The following is a description of a gene set: Human Gene Set: GOBP_LIPID_METABOLIC_PROCESS species: Homo sapiens The chemical reactions and pathways involving lipids, compounds soluble in an organic solvent but not, or sparingly, in an aqueous solvent. Includes fatty acids; neutral fats, other fatty-acid esters, and soaps; long-chain (fatty) alcohols and waxes; sphingoids and other long-chain bases; glycolipids, phospholipids and sphingolipids; and carotenes, polyprenols, sterols, terpenes and other isoprenoids., and this is the list of marker genes: MTMR11, GGT7, DHRS3 (dehydrogenase/reductase 3), PPARD, FUT6, GSTM1, RDH13, ATP5F1A, GAL3ST4, DGAT2, AIG1, CHKB, ST3GAL3, DKKL1, ABHD1, BRCA1, RBP2, ORMDL1, KAT5, LPCAT4, PLTP, CYP4Z1, ADORA1, PLAAT5, PITPNM3, TEX2, MAPK14, UGCG, MBOAT1, H6PD, PRKAB1, ELOVL3, ACSS2, PAFAH2, ABHD11, PDE3B, SPATA18, GPX5, DECR1, RNF213, PLA2G12B, ZMPSTE24, GGCX, TM6SF2, ACBD4, TMEM86B, HSD17B11, ALDH8A1, GDPD3, OXSM, ELOVL4, CYP2B6, PIGC, LRP1, NFKB1, CRK, PLCH1, ENDOU, ATP6V1B1, B4GALNT2, SDR42E1, PIP4K2A, CYP3A5, ABHD12B, FABP2, SLC44A3, GATA6 (GATA binding protein 6), EDF1, CYP2A6, LTC4S, GPR82, MIR192 (microRNA 192), CYP2D6, BBS1, PLA2G3, GFI1, FADS6, ACSL4, PDSS2, TTR, PDK3, ACSL1, OSBPL9, PAQR3, ST8SIA4, SUMF1, PGAP1, ECH1, CHAT, CDS1, PIK3C2G, ALDH1A2 (NCBI Gene Id 8854), ASPG, PDE3A, PCYT1A, LIPN, P2RX1, STAT5A, PLA2G4B, PLPP6, FADS2, SMPD4, CYP4B1, ADM, CYB5R3, CRTC3, DHRS4L2, ECI2, RDH11, APOD, ABCG1, PLA2G5, PIP4P1, GLA, CYP39A1, SLC44A4, GPX4, PTPRQ, MIR1-1, KLHL25, HCAR1, ANO9, ADH5, HACD4, CRKL (CRK like proto-oncogene, adaptor protein), APOA4, FUT2, MIR185, GGT3P, SMPDL3B, LEPR, DDHD1, CYP7B1, HSD17B4, SULT1A3, ASXL3, HCAR2 (hydroxycarboxylic acid receptor 2), GSTM2, MIR127, CYGB, RPTOR, PNLIPRP2, OLAH, B3GALT2, HMGCR, TPRA1, BAX, ACAD10, NFE2L1, ELOVL2, ST8SIA2, BECN1, PLA2G10, GHSR, CRABP2, SCCPDH (NCBI Gene Id 51097), ETFB, PRKAR2B, PDGFRA, GBGT1, UGT2B28, NUDT8, LYPLA2, EDNRB, UCP3, ABHD16B, SORL1, THRA, PIP5K1C, PDSS1 (NCBI Gene Id 23590), TTC7A, PTGIS, PRKD3, ACBD5, ACSBG2, IDI2, FGF19, DHRS7, PIGV, ABHD5, SIRT2 (NCBI Gene Id 22933), PRXL2B, UVRAG, APOB, IDH1, CYP2C18, ACSM2B, TM7SF2, SLC16A1, CRPPA (CDP-L-ribitol pyrophosphorylase A), MTMR9, DNAJC15, ACSL3, LRP5, PGAP6, FLVCR1, ANGPTL4, FA2H, MMUT, TAFAZZIN, PIP4K2C, ACOT12, UGT2A1, PEMT, CFTR, B4GALT6, TMEM150A, PIK3R5, SREBF2, CYP8B1, GNPAT, UGT2B4 (NCBI Gene Id 7363), MTLN, PIGT, SULT1A2, ETFDH, SYNJ1, BGLAP, PCK2, CYP4A22, MCEE (NCBI Gene Id 84693), ST3GAL4, SMPD1, ACSF3, GM2A, WNT10B, B4GALT4, HTR2B, SH3YL1, ABCA1, MIR33A, G6PC1, TBXAS1, LCLAT1, CERS2, CTDNEP1, ITPKB, COQ2, HDLBP, FGF1, ACSM4, PLAA, IP6K1 (NCBI Gene Id 9807), TPP1, ACSM2A, ABCG2, PRKAG2, GPAM, AOX1, CYP2E1, UGT2B17, PECR, BMX, RIDA (reactive intermediate imine deaminase A homolog), ATM, ADHFE1, SPTLC2, APOF, GGT1, PDK2, ATP1A1, PI4K2A, NUDT19, PLD6, LPIN2, EFR3A, SLC27A3, PTPMT1, SAMD1, INPP5J, HDHD5, NEU3, ALDH3A1, PI4KB, HEXB, CHKA, CYP26A1, IMPA2, ID2, ACOX1, MFSD2B, B4GALNT1, ACAA1, ZPBP2, MPPE1, CPT1B, SDR16C5, SMPD2 (NCBI Gene Id 6610), SPHK2, MBOAT2, NUS1, RDH14, LRAT, ADH4, TMEM135, C20orf173, VLDLR, TPK1, CES1, ILVBL, CYP2A13, ALDH1L2, RDH8, MECR, MED1, IP6K3, SREBF1, ABCA3, DGAT2L6, IAH1, CYP4A11, HPGDS, DGKI, SPTSSA, AKR1C3, OPA3, ACOT8, NR0B2, ITPKC, PLD4, DGKE, CAPN2, SPHK1, FKRP, ALKBH7, FAH, PLSCR1, PCYT1B, AVP, AFP, CES2, C3, MIR16-1, TSKU, KPNB1, NAGA, ST8SIA1, ENSG00000293349, PLA2G2C, TBL1XR1, APOA1, FABP3, RUBCNL, CH25H, ABCA8, LEP, GGTA1, PRKCE, PRKD2, PIGH, LIPK, UGT1A6, POR, GOLM1 (NCBI Gene Id 51280), PLAAT3, CNEP1R1, CREB1, GPER1, SGMS2 (NCBI Gene Id 166929), PLD1, MFSD8, PDK4, AVPR1A, NR1H4, ABHD8, GDPD2, FAM135B, FUT5, MIR98, FAXDC2 (fatty acid hydroxylase domain containing 2), ENPP6, SULT1E1, CTHRC1, MGST2, LGMN, NSDHL, ETNPPL, SEL1L, PRKAA2, ISYNA1, PLD2, LPGAT1, PEX2, PLA2G2D, PIGU, TYRP1, ADGRF5, TNXB, MBOAT7, PLEKHA1, NCOA2, INPP5B, ACOXL, ABCD4, NEU2, ALDH1A1 (NCBI Gene Id 96075), ZNF202, A3GALT2, ALOX5, DGKH, OSBPL8, ADTRP, SIRT3, FITM1, PNPLA7, DGKD, DISP3, ACACA, INPP5A, MGLL (monoglyceride lipase), CPT2, NAGLU, CPT1A, GDPD5, ABHD2, HSD17B13, SFTPB, PORCN, ACOX2, FAAH2, HMGCLL1, ZNF750, OSBPL10, PAQR4, BDH1, APOC1, MIR548P, SLC22A13, HADHA (hydroxyacyl-CoA dehydrogenase trifunctional multienzyme complex subunit alpha), FMO2, GGPS1, SULT1C3, ECHDC3, MIR27A, IFNG, DEGS2, ORMDL3, IGFBP7 (insulin like growth factor binding protein 7), LRCOL1, LDAH, APOBEC1, WNT4, MTMR14, PLCG1, APOBR, AGPAT2, BCAT1 (branched chain amino acid transaminase 1), NEU4, PLIN1, HPS6, AMACR, PNPLA1, MIR766, PLCH2, ABCA7, PLCL2, PLAAT2, PLD3, PIK3CB, AADAC, TECR, PPT2, CTH, DHRSX (NCBI Gene Id 207063), MTMR12, GPRC6A, MBOAT4, ERRFI1, CERT1, CCN1, HACL1, ACSM5, TREM2, ETFA, TYSND1, FAR2, PLA2G2F, CYB5R2, APOC4, CLSTN3, EBP, AKR1B10, CDIPT, ADIPOR2, PC, GNAI1, ACOT7, GDF15, TTPA, HADHB, ADH1C, LCT, DAGLA, ACAT1, LPCAT2, RDH10, TPTE2, SERPINA12, AGPAT5, PRKAB2, PANK2, CUBN, NEU1, VAC14, CD36, NSMAF, LIPF, KDSR, PLA2G15, GPR180, NR1D1, SCARB1, PLB1, MIR132, GBA1, ABCB11, EIF6, PROX1, GK2, SULT4A1, BCO1, NR1D2, FUT9, UGT1A9, PIK3R1, DOLPP1, CYP11B2, PIGG, PIGK, ABCC9, DKK3, NR5A1, FIG4 (NCBI Gene Id 9896), HTR2A, PGAP3, GPAT2, EGR1, PLBD2, ZNF670, RPE65 (retinoid isomerohydrolase RPE65), DPEP2, CAT, CBR1, CIDEB, LPA, GSTA1, FUCA1, CHP1, MCAT, RBP1, ACSS3, HSPG2, CWH43, HSD17B10, WDTC1, CROT, ACACB, CYP4F2, MIR206, MIR27B, HSD3B2, ABHD3, PLPPR5, PIGP, UGT1A1, AGK, HTD2, G6PD, PTGR2, GC, ALOX15B, NDUFS6, PLCE1, ACLY, CLN3, SGPP1, DEGS1, ACADVL, PLA2G4F, HSD3B7, CERS5, PI4KA, HNF4A, LDLRAP1, PLA2G1B (NCBI Gene Id 5319), MIR29B1, NR1I2, SLC27A2, CYP2U1 (cytochrome P450 family 2 subfamily U member 1), GSTM4, PGP, VPS54, DGKA, AWAT2, KAT2B, MVD, ALDH3B2, AACS, CERS1 (NCBI Gene Id 10715), ELOVL6, PLCB4, PIGL, OGT, DAGLB, UGT1A4, CERKL, MOGAT3, LRP2, MTMR10, AKT2, UGT1A7, MTMR3, MBTPS2, PRMT3, ACADSB, MOGAT2, CYP1A1, HAO2, HSD11B2, ACAD9, CYP2C8, ACSS1, GLB1, HACD1, CIDEC, SCARF1, TWIST1, LMF1, CERS6, ACOT1, ZFP69, PLA2G6, DPM2, B3GNT5, SDS, PLAGL2, EPHX1, PSAP, ALDH3A2, SULT2B1, TAMM41, COMT, FDPS (farnesyl diphosphate synthase), INPP4A, PIP5KL1, EPHX3, ALOX12B, ASAH2, IP6K2, HSD17B2, ARV1 (NCBI Gene Id 64801), PLBD1, OSBPL3, SLC30A5, DHCR24, GGT5, GGTLC1, CERS3 (NCBI Gene Id 204219), CLPSL2, PIGN, BSCL2, FMO4, THEM4, ACOT2, DDX20, INHBA, NR3C1, SPTSSB, APOC3, PLCZ1, SLC44A1, PLPPR3, M6PR, FGF23, PROCA1, FABP5, GK5, CHST10, SLC27A1, PTGS1 (NCBI Gene Id 5742), AQP8, OSBPL7, ERG28, PGAP2, SCD5, SIRT6, RDH5, SLC22A24, CYP7A1, LHCGR, ACER1, GPR146, APOH, PAM, ACADM, DHH, EEF1A2, HSD17B3, TNFAIP8L3, IDI1, XBP1, LPCAT1, PNPLA4, INPP1, STARD3, TMEM43, PIK3CA, PIGA, HSD17B6, ALDH3B1, GAL3ST3, PLPPR2, ST8SIA5, DHRS9, AVIL, OSBPL6, PI4KAP2, CYP27C1, CLN8, HSD17B14, EDN2, PITPNB, BCO2, PLA2G4C, SERPINA6, RORA, PIP4P2, PIAS4, PLPP3, PRKAG3, ELOVL7, ADGRF1, PAFAH1B3, SERINC1, PITPNM1, EDN1, AKR1C1, INPP5F, CPS1, CYP3A4, PITPNM2, SORBS1, PIP4K2B, PIK3CD, SMPDL3A (NCBI Gene Id 10924), ITPKA, NDUFAB1, PAFAH1B2, DBI, SLC27A4, PLPP4, ADH6, DNAJC19, HINT2, FITM2, PTEN, PLA2G7 (NCBI Gene Id 7941), GAL3ST2, ADRA2A, GDPD1, RICTOR, DPM1, MVK, MIR182, PIP5K1A, SNAI2, BMP6, MIR342, LACTB, CYP1B1, CYP27A1, B3GALT1 (NCBI Gene Id 8708), APOC2, SCPEP1, SPP1, GBA3, AGPAT1, MID1IP1, SMG1, ACAD11, ANGPTL3, INSIG2, ANGPTL8, ST6GALNAC3, ABCB4, TMEM38B, SOX9, GSTA3, CEPT1, ASAH1, GGT6, PLA2G2A, APOL2, CYP3A7, CYP1A2, UGT1A10, CYP2F1, ZBTB20, OCRL, ERLIN2, UGT2B11, CYP46A1, PTPN11, PIK3R3, OSBPL1A, UGT2A2, PSAPL1, SPNS2, TMX1, ARMC5, ADIPOQ, PLCD4, CYP4F11, PLCG2, KIT, PIGM, ALDH1A3, CYP3A43, HAO1, ABCA2, ECHDC1, GPCPD1, MTM1, CYP26C1, CIDEA, SRD5A1, ACSF2, FUT4, SELENOI, GPAA1, LSS, GPIHBP1, INPPL1, PRKCD, GPLD1, CYP27B1 (cytochrome P450 family 27 subfamily B member 1), CYP4X1, LPCAT3, ACAD8, FAR1, AWAT1, ADH1B, CERS4, PISD, TSPO, BDH2, NKX2-1 (NK2 homeobox 1), CYP19A1, SERINC2, PPM1L, AGPS, PDGFB, MBTPS1, B4GALT3, STAT5B, AGT, ST6GALNAC6, DHCR7, MECP2, PIK3C3, GALC, B3GALNT1, SULT2A1, CLCN2, CGA, RDH12, PPARGC1A, UGT8, PLCXD2, PLPPR4, MAPK1, PLCB3, LGALS13, CLPSL1, MIR195, CYP2C19, FAAH, BCL11B, PLCL1, FUT7, PRLR, LIPI, ST8SIA3, IL1B, PIGQ, EBPL, IPMK, PBX1, ARSA, ESR1, GGTLC3, NAAA, ABCD2, MIR9-1, CREBL2, ECHS1, SEC14L2, FDX1, ACSL6, FADS1, CHPT1, ABO, THEM5, CYP26B1, ASAH2B, APPL2, SCAP, DPM3, AKR1B1, PDK1, ECHDC2, AKR1C2, PLA2G12A, MBLAC2, PNLIPRP1, PNPLA3, PTGDS, EPHX2, HYCC2, SH3GLB1, HMGCS1, TTC7B, SIRT4, CPNE1, NCOR1, SCD, GSTP1, ACSM3, ABHD16A, APOE, NR0B1, TECRL, CYP2A7, HMGCS2, AKR1B15, SLC22A4, ACAT2, HADH, LIPH, PLPP2, PCCA, PTGR3, ST3GAL5, PLP1, SLC25A17, PLA2G2E, HSD3B1, CYP4F12, LPIN1, DHRS2, SLC27A6, SLC45A3, VAPA, NR1H2, MALRD1, FUT3, ACSM1, LTA4H, NPC2, GAL3ST1, ABCG4, CLPS, PLPPR1 (NCBI Gene Id 54886), INPP5E, STAR, LIPJ, MSMO1, FADS2B, FNTB, LYPLA1, DDHD2, CYP11B1, CLN6, SPTLC1, ACER3, APOL4, DHRS4, GALR2, APOL1, PIGW, CPT1C, MTMR7, INPP4B, CEBPA, PCK1, LPL, GIP, ACSM6, NR5A2, PTGS2, AKR1D1, CRLS1, CEL, ACOT9, PIGB, PER2, SC5D, HTRA2, CRAT, ETNK2, AGPAT3, GLT6D1, ACP6, BMP5, ACP3, AKR7A2, DAB2, SERINC5, B3GALT4, FABP6, OSBP, MOGAT1, ACADL, DGKB, PRKD1, THNSL2, MTMR8, SIRT1, BPNT1, ORMDL2, LIMA1, PIGO, INSIG1, DHRS7B, APOA5, C7orf50, COX10, DHDDS, HACD3, ENPP2, PIPSL, CYP2C9, AKT1, CYP2R1, DGKQ, ALOXE3, GK, CYP51A1, UGT1A3, HTR2C, FMO1, HMGCL, MIR30C1, PGK1, DHRS4L1, MIR96, FGFR4, PEDS1, LIAS, NPC1, APOA2, PI4K2B, PNPLA2, PMVK, MTMR6, PTDSS1 (NCBI Gene Id 9791), ETFBKMT, UGT1A8 (UDP glucuronosyltransferase family 1 member A8), OXCT2, HSD17B7, FSHB (NCBI Gene Id 2488), PLPP1, PCYT2, HSD11B1, ACOT11, SQLE, MLST8, TREX1, UBR4, SGPL1, SACM1L, ACOT13, FBXW7, ACSBG1, PLA2G4A, PLCXD3 (NCBI Gene Id 345557), ST6GALNAC5, SIK1, ABHD12, ACBD3, VSIG2, ATF2, PGS1, ACER2, AKR1C4, LPIN3 (NCBI Gene Id 64900), RARRES2, NUDT7, PLPP5, SNAI1, PTGES2, ITGB8, PRKG1, PLCB1, PIGZ, SCARB2, ST3GAL1, PLCD3, INPP5K, PON1, BCKDHB, GDE1, LIPE, ACSL5, ACOX3, CYP4F3, PIK3R4, MTMR4, DPEP1 (dipeptidase 1), LCAT, PAFAH1B1, LRP8, PLA2G4D, SDR9C7, HSD17B12, SAMD8, LRP10 (NCBI Gene Id 26020), PEX7, FGFR1, AGPAT4, RDH16, ACOT6, OXCT1, CREM, GAL, IVD, PDE8B, ALOX15, ASMT, DGKZ, BAAT, MFSD2A, IRS1, PPARG, SCT, MTMR2, TRIB3, CACNA1H, AASDH, GPX1 (NCBI Gene Id 2876), OSBPL2, RLBP1, INPP5D, ABHD6, MIR204, THRSP, CDS2, PM20D1, CYP2S1, P2RX7, B4GALT1, CBR4, PRKACA, CD74 (CD74 molecule), CLU, PNPLA6, ERLIN1 (NCBI Gene Id 10613), IMPA1, CAV1, SULT1A1, ABCA5, FMO5, SGPP2, PIBF1, MLYCD, HSD17B8, ACAA2, OC90, SNX17, DGKG, TIPARP, AGTR1 (NCBI Gene Id 9449), PDGFA, NR1H3, NCEH1, STS, NAA40, ST8SIA6, SDSL, CYP21A2, MACROH2A1, EHHADH, GBA2, RBP4, PXMP4, TM9SF2, PRKAG1 (NCBI Gene Id 5571), SDR42E2, TMEM68, FADS3, SCP2, GPS2, CHRM5, HPGD, ELOVL1, PTGR1, TTC39B, PRLH (prolactin releasing hormone), RAB38 (RAB38, member RAS oncogene family), DGKK, AUH, MIF, JAZF1, GCDH, BCKDK, ABHD4 (NCBI Gene Id 63874), IL1RN, GPR31 (G protein-coupled receptor 31), LIPG, AJUBA, PNPLA5, PIP5K1B, ATG4A, PNPLA8, A4GALT, MGST3, MTOR, CYP2J2, AKR1A1, LONP2, REST, LBR, STARD4, ABCC1, ADH1A, CCDC3, SLC35C1, SULT1A4, FAM135A, PEX5, AOAH, TNF, CETP (cholesteryl ester transfer protein), C1QTNF2, SLC16A11, LARGE1, UGT2B10, ENPP7, LIPM, DGAT1, PLAAT4, SYNJ2, SLC44A2, SLC27A5, ST6GALNAC4 (NCBI Gene Id 27090), CPNE7, ALK, DECR2, MTTP, PHB2, SOAT1, FDFT1, FECH, DHRS11, GLYATL3, RAB7A, HSD17B1, STUB1, PIK3C2B, CSNK1G2, PLCXD1, YWHAH, RETSAT (NCBI Gene Id 54884), PIKFYVE, HYCC1, IL4, CERK, HACD2, GPAT4, UGT2B15, ACADS, PTPRN2, PNLIPRP3, CYP24A1, PRDX6, BLOC1S6, SOAT2, SESN2, CEACAM1, B3GALT5, SGMS1, NPC1L1 (NPC1 like intracellular cholesterol transporter 1), ATP5F1B, SRD5A2, SPTLC3, ATP8B1, FASN, PLCB2, LHB, PLA2G4E, AGMO, MORC2, PTDSS2, SRD5A3 (steroid 5 alpha-reductase 3), PTGES, EFR3B, QKI, CYP2W1, PPT1, ST3GAL6, GLYATL2, SPART, PRKAA1, PLIN5, ACBD7, GNB3, ADH7 (alcohol dehydrogenase 7 (class IV), mu or sigma polypeptide), NKX2-3, FMC1, PPARA, PIGS, APOL5, LIPC, CYP4V2, CRH, PTPN22, ATG14, CRYL1, FUT1, HEXA, PRPF19, ST3GAL2, PIGX, PIK3C2A, UGT2B7, PGAP4, CD2AP, ALOX12, CYP11A1, ACOT4, PLA1A, DOLK, KBTBD2, PLCD1, SERPINA3, FDXR, SCNN1B, DCAF5, ERFE, PIGY, BTN2A1, TNFRSF1A, LIPA, RORC, ABCD1, CYP4F22, PCCB, GGT2P, LIPT1, SERAC1, ABCA4 (ATP binding cassette subfamily A member 4), CYP4F8, ABCA12, UMOD, SERINC4, ABCD3, OMA1, IRS2, ELOVL5, OSBPL5, PHYH, SNCA, MTMR1, PIGF, LDLR, NAPEPLD, SLC44A5, NPHP3, CYB5R1 (cytochrome b5 reductase 1), TMEM86A, ZFP92, ETNK1, PLAAT1, PITPNA, ADIPOR1, INS, PTGES3, PIK3CG, GDPD4, BPNT2, ANKRD23, PEX13, GGTLC2, PNLIP, SHH, MLXIPL, SMPD3, CAV3, CYP17A1, B4GALT5, TRPV1, BMP2, ECI1, PCSK9, GPAT3, BBS4, TLCD3B (NCBI Gene Id 83723), ABHD15, RBP3, BCAT2